The following is a description of a gene set: Human Gene Set: GOBP_PROTEIN_TRANSPORT studied in species Homo sapiens The directed movement of proteins into, out of or within a cell, or between cells, by means of some agent such as a transporter or pore., and this is the list of marker genes: YIF1A, SNX12, RGPD5, TCIRG1, AP3S2, ADIPOQ, HPSE, WASHC2C, ARF1, SRP54, AP5B1, VTI1A, RAB3A, ARFGEF2, COPZ1, TUNAR, SNAP91, PEX1, DENND1B, OAZ3, VPS37A, CDKN2A, OPRM1, CD200, TNPO1, TIMM10, TOM1L1, CDK5, APP, ARL8B, SNX8, VMP1, STX18, TANGO2 (transport and golgi organization 2 homolog), G6PC2, S100A13, SNX27, SFT2D3, CHMP4C, MYOM1, GPR68, ARRB1, TGFB1, SORT1, MYO5A, COPB1, NUP88, TVP23B, GFAP, EDEM2, PPIA, TVP23A, TRAM1, SNX9, F2, FAM3B, ZFAND1, SLC8B1, MLXIPL, NOTCH1, SOX4, GPLD1, ARFGAP2, UMOD, ACSL3, PORCN, EHBP1, PHPT1, USE1, PAFAH1B1 (NCBI Gene Id 5048), MIR130B, AP3M1, RSAD2, RHBDF1, TOM1, TNF, BET1L, CNIH4, TOMM6, RAB1C, RIMS2, ITPR1 (NCBI Gene Id 619543), IPO8, TAP1, PCSK5, STX8, ZW10, RIMS1, TRIP11, LIN7A, REST, TMED2, PKD1, TIMM23, TIMM17B, LRP1B, LRP1 (LDL receptor related protein 1), BRSK2, CDK1, PPP3CA, NPIPA1, KPNB1, LRRC8A, ZIC1, FOXA2, SAR1A, SURF4, TOMM20L, SEC61A1, NR0B2, PTPRN2, SNX31, PRF1, COG2, ASTN2, SLC9B2, GPER1, KIF20A, CANX, SCAMP5, TMED6, SPIRE2, F2RL2, CPT1A, EXOC6B, BLOC1S6, GOLPH3, MIR301B, ACTN4, TNPO3, FRAS1, FUT10, DNAJC13, NPFF, NR1D1, LONP2, RILP, PDIA4, SEC24C, ANGPT1, CETN3, FAF2, RAB1A, VPS45, EXOC6, JAKMIP1, CLU, FHIP1B, MAPK14, SNX20, UBR5 (ubiquitin protein ligase E3 component n-recognin 5), CEP41, P3H1, SEC24B, TFAP2B, TIMM9, VAMP4, ACD, XPO4, NUP58, NCOA4, EIPR1, SEH1L (SEH1 like nucleoporin), ABCG1, ATG10, RABL2A, RAC1, TOMM22, SPRN, RAB3IP (NCBI Gene Id 64325), PARK7, PTPRN, KCNN4, PPARG, ACAP1, KDELR3, KPNA2, CYB5R4, ARRDC4, LMAN2, UBE2J1, PICK1, VPS39, RAMP1, GIP, VAMP5, IL10RA, MYRIP, PCM1, HSPB1, WASHC1, RGPD4 (RANBP2 like and GRIP domain containing 4), NAPB, VPS54, FKRP, LARGE1, GPR89A, DMAP1, AFM, HDAC3, XPO7, PRKCB, AP4M1, NMD3, IST1, RAB11FIP1, SAMM50, NUP205, NDP, NUP54, VPS13C, IFT20, EXOC2, CD3G, APPL1, MON2, WLS, TGFB3, INSIG1 (insulin induced gene 1), LRP2, NAGPA, MYO1D, CBL (Cbl proto-oncogene), FAM3D, LCA5, SERGEF, EGR2, KPNA4, SNX33, B3GAT3, CARTPT, GRIP2, PRKAR1A, GRPEL2, SNX22, CLTRN, ISL1, SIX3, ADTRP, AP3D1, PRAF2, ACVR1C, CRYZL2P-SEC16B, NPLOC4, RAB17, CHMP3, KDELR1, PEX12, CTSA (cathepsin A), RAB3B, TSG101, PEX5L, AIFM1, SH3TC2, VPS36, VAMP7, RABEP1, TSNARE1, CPLANE2, GOLT1B, SCRIB, AHCTF1, EMD, AP3S1, IPO9, WASHC2A, DNLZ, AMN, PITPNM1, KIF5C, DENND10 (DENN domain containing 10), HEATR3, SUMO1, VPS35, ANG, ARF6, CHMP5, CHMP7, CHMP4A, ARFIP1, COPG2, MIR148A, IER3IP1, RAB9A, BLOC1S3, SEC61G, YWHAE, GOLT1A, ADAR, HLA-DRB1, HADH, TAP2, AKAP8, STXBP5L, ASPH, IFT56, APPL2, C1QTNF12, GRIP1, STX3, TERT, CETN2 (NCBI Gene Id 812), GNAZ, MIR29B1, TTC8, GNAO1, EPM2A, PRR5L, ARHGEF5, NEURL3, WDR11, FRMPD1, NETO1 (NCBI Gene Id 81832), GHSR, STK3, LRRC7, NUP153, ZG16, GPR119, SMURF1, PREPL, MMP12, ING1, CELA2A, HFE, SLC2A2, SYNDIG1, PLK3, ARFRP1, EFCAB7, ARF5, DENND1A, VIPAS39, KCNJ11, SFT2D1, RAB26, SNAPIN, FCHSD2, RABEP2, RAF1, CTNS, TTN, NR1H3, AP1S3, TSC2, SYTL4, SYTL2, BCR, PSEN1, COG6, PEX6, ELMOD3, TIMM10B, ARFGAP3, NUP43, SEC61B, HSPA8, RILPL1, SNX21, SNX6, PEX10, RUFY3, TFRC (NCBI Gene Id 7037), FKBP1B, TOMM70, RAB11FIP2, SPTBN1, SREBF1, YIPF5, ATP2C1, NR4A1, STEEP1, ANK2, EXPH5, TRIM23, RAB5B, NEUROD1, DNM1L, LEP, SNX19, RAB11FIP5 (NCBI Gene Id 26056), CAV1, MYH10, PIK3R4, CTAGE4, PFKL, HNF4A, JUP, PCK2, NKX6-1, ARCN1, AAGAB, GHRL, CRH, DRD4, NUP37, APBA2, NPM1, KIF5B, SYTL1, RBM22, ATF2, DTX3L (deltex E3 ubiquitin ligase 3L), RAB3C, RAB2A, CHP1, TESC, ATP13A2, PKDCC, DGKD, TMEM167A, ARL11, PTPN1, PSMD9, SIX2, PEX19, REEP2, KCNA5, TM7SF3, NF1, AP4E1, LYPLAL1 (lysophospholipase like 1), VPS11, LTBP2, UEVLD, VIP, VTA1, RAB24, TUBA1A, HM13, TIMM44, RAB27A, PPP3R1, TACR2, MTTP, PRKCD, IPO4, PCID2, SNX7, CLN3, MCFD2, STX7, TCF7L2, DOP1A, GSK3B, MON1A, ACSL4, RANBP3L, RABGAP1L, HNF1B, KRT18, TIMM17A, MACF1, KIF3B, IFNG, SEC22C, GOSR2, TOMM40L, NEO1, CD24, RAB19, F2RL1, GNAS, IRGM, BMP6, TMED5, GPIHBP1 (glycosylphosphatidylinositol anchored high density lipoprotein binding protein 1), PDCD6IP, CBLN1, SEC22A, MIA3, MIR19B1, CLOCK, NUP155, CASR, EDEM1, IRS2, IL12A, NAPA, ARF4, MIR146A, AP3M2, BAG3, WWP2 (NCBI Gene Id 116013), VPS26A, IDH2 (NCBI Gene Id 3418), SFT2D2, SLC15A3, AP1B1, CAPN10, RAB7A, VCP, RAB39B, NACAD (NAC alpha domain containing), RIC1, EFNA5, HYAL2, HOOK1, E2F3, AP1AR, YKT6, NECAB3, SPAG17, IPO11, VPS13D, CCL5, STX5, HSP90B1, NUP98, RAMP3, CHRM1, SNX13, KIF17, IFI27, ANKLE1, NUP93, RABGEF1, GGA1, GOLGA7, ILDR2, WASHC4, JAK2, ABCA12, RAB22A, SCG5 (NCBI Gene Id 6447), STRADA, GOLPH3L, BCAP31 (B cell receptor associated protein 31), NECAP2, PEX26, CTAGE15, TMED1, RAPGEF4, RHOB, UNC13B, PEX14, SNAP29, GCG, MED1, SLC7A11, SIRT4, SERP1, CLIP3, TIMM50, SNX15 (sorting nexin 15), STRADB, EDNRA (endothelin receptor type A), CD36, COG7, ADAMTS9, STX16, MLC1, IFIT1, ENSA, RAN, ARL4D, TRPA1, ADRA2C, VPS37B, ZFAND6, MIA2, RAB11B, RPAIN, COG1, MACIR, MTCH2, CLSTN1, AP1S2, PRKN, SNX32, ATG4C, BLZF1, GOLGA4, SNX1, BMAL1, NASP, RAB23, VPS37D, KCNB1, NLGN2, AP5M1, LYST, HSPD1, ERP29, KPNA3, MVB12A, EXOC7, AP5Z1, MX2, CLTA, COG3, ARL6IP5, PLEKHF2, RAB25, BECN1 (beclin 1), RAB41, TLK1, RAB10, SCFD1, VPS33A, TMED10, KIF5A, GDI2, CDKN1A, RAB1B, ARL6, AKTIP, PTPN14, NUP133, BBS5, VPS33B, AGAP1, CCDC22, HGS, SMAD3, TIMM13, TOMM20 (NCBI Gene Id 9804), FGG, DNAJC1, NDFIP2, SELENOS, TMEM115, OAZ2, VLDLR, CD38, VPS8, ATG4B, UHMK1, MTX2, CBLN4, STX1B, TMEM132A, APOE, SNX14, PML, MIDN, AP2B1, APPBP2, RD3, NUP214, FRAT1, B4GALNT2, PCLO, SFN, GPR27, CCHCR1, ABRA, DOC2B, SPIRE1, HEATR5B, CHMP2A, ARL5C, ATG7, RANGRF, MICALL1, UCN3, SNX17, GABARAP, CD81, CALR, TM9SF4, BBS2, UCP2 (NCBI Gene Id 7351), CFL1, GGA2, CADPS, NXF1, ZMAT3, RABL2B, PEX16, WASH3P, ARRDC2, NUP50, AP4B1, SELENBP1 (selenium binding protein 1), HERPUD1, EI24, TRARG1, CD63, DAB2, ABAT, ZBED6, PRKCA, SVBP, RACK1, RAB29, SCAMP2, SYS1, SENP2, SNX4, ORAI1 (ORAI calcium release-activated calcium modulator 1), SELENOT, SLC7A6OS, HOOK2, MC4R, PRKCE, TIMM8A, SNX11, RAB12, AP1G2, TFR2, BMP4, ENTR1, PPM1F, SLC51B, SHH (NCBI Gene Id 6469), AAAS, GDI1, MIR199B, FOXO1, P2RX7, GLUD1, LCP1, MIR30C1 (NCBI Gene Id 407031), TOMM7, RAB28, RFX6, TMEM97, PIK3R2, B2M, TMED9, RIPOR1, OAZ1, ADORA2A, AUP1, CHCHD4, SRPRA, ARL4C, STX19, IFT27, POM121, F2R, GRIPAP1, BCL3, RAB3IL1, RANGAP1, STX17, NADK, NUP188, UFD1, SDAD1, KPNA1, YOD1 (YOD1 deubiquitinase), AP2A1, PLA2G1B, APOD, GPR89B, KCNQ3, CPLX1, FAM53A, NUTF2, NXT2, FAM53C, CCDC93, STX12, SYT7, NFKBIA, TRMT10B, SEC24D, APBA1, NOS2, RGPD3, ARF3, SCG2, COG5, ARHGEF2, GOPC (NCBI Gene Id 57120), TMEM30A, CHMP2B, DUOXA2, ANP32B, IPO7, NUP160, ELMOD1, RRBP1, NMU, OPTN, ICE1, SLU7, CAMSAP3, RPH3AL, NECAP1, CCDC91, RAB32, BBS7, SACM1L, CHMP6, TANGO6, PLEKHA8, AGK, DERL1, CTAGE8, ARL17B, PAM16, IL1B, XPOT, COPZ2, STAM2, SMAD2, GLE1, STAM, CPLX3, RBM4, DNAJC14, VAMP8, C1QTNF5, STX11, UBAP1 (NCBI Gene Id 51271), REP15, BET1, BBS4, HIF1A, CHMP1A, ATP6AP1, IL13, RABL3 (NCBI Gene Id 285282), STXBP1, DAG1, ATG14, ADCY5, PARP11, AP3B1, SNUPN, NR1H2, NDEL1, AP1M1, PCNT, RINL, OR51E2, SEC23IP, PREB, MYO7A, PEX13, ARFIP2, C2CD2L, SEC16B, RAB6C (NCBI Gene Id 84084), C1QTNF3, ANK3, CDH1, IFT25, MLPH, FMN2, ARL14, VPS26B, SIRT6, PIK3R1, SLC35D3, PEX2 (NCBI Gene Id 5828), PDX1, IPO13, BAIAP3, MAMDC4, KPNA5, CHML, CUBN, ANXA13, LAPTM5, NUP62, RAB8B, GLP1R, UFM1, SLC4A8, NUP85, CLSTN3, AP1G1, NSG1, RAB6B, GAS6, HAP1, VPS50, COPA, TRAF3IP2, HPS6, ZDHHC17, NPAP1, ARRDC1, MAVS, SEC13, AP1S1, FUZ, FUT11, PDCD6, PPM1A, KIF13A, TIMM21, ARHGAP1, ANKRD1, CDK16, ZFYVE16, PRKACA, GCK, SYT4, HOOK3, NGFR, COL1A1, SNX16, SLC12A2, HCAR2, BBIP1, SIL1, SNX24, M6PR, TMEM30B, GNPTAB, TBC1D5, STX10, TIMM29, SEC62, RAB3D, CALCRL, CADPS2, INS, ABCA1, EXOC1, PFKFB2, BBS1 (Bardet-Biedl syndrome 1), LMAN2L, PGRMC1, TNKS, CAVIN1, MAP1LC3C, PTPN11, NR1H4, TBC1D13, ENY2, RILPL2, DMBT1, NUP35, RAB27B, EXOC4, VEGFC, OS9, VSNL1, ERLEC1 (endoplasmic reticulum lectin 1), SCARB2, AP1M2, SORCS2, STXBP4, DERL3, ASPSCR1, GUK1, SORL1, ANO1, RINT1, NDFIP1, SYVN1, CABP1, UNC119, DERL2, YIF1B, PTPN23, AP5S1, MTM1, POLA2, MDFIC (NCBI Gene Id 29969), MIR766 (microRNA 766), RAB5A, STX2, TBC1D17, RP2, TRPM4, DNAJC27, SNX25, XPO1, PEX7, AP2M1, NDUFAF2, FGB, WASHC3, SNAP25, SCAMP4, MIR199A1, AGAP2, RTN2, CHP2, CD74, PGAP1 (post-GPI attachment to proteins inositol deacylase 1), NXT1, MTNR1B, APOB, RAB4B (NCBI Gene Id 53916), ADRA2A, STXBP2, CYP51A1, SYK, BARD1, IL1RN, DNAJA1, SYTL5, LAMP2, SUCNR1, AKAP5, DENND4C, AP2A2, GORASP1, RAB11A, CHRM3, CHM, RAB4A, XPO5, PEX5, HSPA5, UNC119B (NCBI Gene Id 84747), SNX30 (NCBI Gene Id 401548), GRPEL1, GAL, SEC31B, IL1A, SLC16A1, RGPD2, ARRDC3, POM121C (NCBI Gene Id 442581), COPB2, RAB14, PHAF1, RANBP17, MYH9, NUP42, MTCH1, PTTG1IP, TNPO2, PLEKHM1, SLC25A22, MPC2, FAM76B, HSPA4, RAB3GAP2, RAB38, TRIM3, RGPD8, NNAT, TLR4, RAB6A, SLC15A4, SEC22B, ZFAND2B (NCBI Gene Id 130617), RAB5C, CBLB, CMTM6, DRD2, CSK, EDNRB, TMED4, CCDC186, AZGP1, VPS26C, PEX3, INHBB, ADCYAP1, TIMM22, FAM53B, DNM2, STX1A, CEP290, RAB7B, TMEM9, AFG2B, RGPD6, LYPLA1, SEC61A2, GCKR, DYNLT1, ACVR2B, C17orf75, RAB33B, C2CD5, RANBP6, CLTCL1, CORO7, RAB6D, STEAP3, GCC2, PIM3, ATG4A, TIMM23B, ARRDC5 (arrestin domain containing 5), SNX3, LRSAM1, MBTPS1, VPS18, RAMP2, DNAJC15, IRS1, ARFGEF1, ARL5A, IGF1, NDUFA13, NEURL1B, SYBU, BMP8A, LMNA, ZC3H12A, MIR19A, MIR93, DTNBP1, RAB37, SELENOK, CTDSPL2, SIRT7 (NCBI Gene Id 51547), SLC15A5 (solute carrier family 15 member 5), PLCB1, PARD6A, CAMK2G, IFT22, MAFA, CTAGE9, APBB3, SEPTIN8, SPG11, RAB21, FFAR1, JAGN1, SLC15A1, STAT3, RCN3, APBB1, RAB11FIP3, TIMM8B, SAA1, SEL1L, GABARAPL2, MCOLN1, ATG16L1, TMED3, RABIF, MYO6, SAR1B, LRRK2, YWHAH, COPG1, CD2AP (NCBI Gene Id 25916), PIK3C3, MCOLN2, CAMK1, TRAM1L1, ATG16L2, GPRC6A, LIN7C, MAP1A, CD33, DNAJC19, SLC1A1, CFTR, TVP23C, NUP107, GNPTG, PHB2, STXBP3, FRMD4A, GNAI1, CLTC, UBE2Q1, ADAM8, FFAR2, EXOC3, ATG4D, ERC1, MCU, RGPD1, HMGCR, EHD1, BICD2, FRAT2, PDE8B, FERMT1, WASHC5, SEC24A, RAB39A, HSPA9, FGA, EHD3, USP9X, MON1B, GNA11, ARL1, HNF1A, KCNK16, SNX2, KDELR2, CEP131, RUFY1, EIF4ENIF1, STK4, VPS41 (NCBI Gene Id 27072), VPS4A, USO1, NACA, GAPVD1, SYTL3, KRT20, SUFU, SEC23A, PPT1, BLK, UBAC2, PKIG, COMP, OSBP, DOP1B, PPID, COG4, CLTB, KPNA7, RSC1A1, TOM1L2, AP4S1, ALOX5, VPS13A, TREM2, VAMP2, HSP90AA1, MDM2, NUP62CL, TXNIP, ADCY8, TENM1, FGF9, CENPF, LMF1, MTX1, KIF18A, MCM3AP, RAB15, IPO5, PLA2G6, GPM6B, ARFGAP1, PFKM, TRIM37, RAB8A, DESI1, ARL4A, TOMM5, TMED7, TOMM40, MVP, COMMD1, RAB2B, LMAN1, KIF3A, SQSTM1, RAPGEF3, LIN7B, AKT1, YWHAB, VPS4B, MVB12B, ROMO1, RFFL, VPS35L, KTN1, FLNA, PHAX, SEC23B (SEC23 homolog B, COPII coat complex component), PER2, PDCD10, COMT, ITSN1, GSDMD, ADAM9, AHCYL1, VTI1B, EIF2D, CTAGE1, RAB36, SMO, ZPR1, SLC30A8, EPHA5, DRD1, NACA2, TLR2, SNX5, BCAP29, HERC2, RHBDF2, TARDBP, TGFBRAP1, DLG2, TGFB2, COPE, EPS15, PPP3CB, KPNA6, CCN3, PRKD1, SCAMP3, CNST, RPGR, SEC16A, MIR128-1 (NCBI Gene Id 406915), AFTPH, ANKRD27, ARHGAP33, ARL3 (ADP ribosylation factor like GTPase 3), SYNRG, STX4, POM121B, STX6, RHBDD1, CTAGE6, GLI3, TRIM28, GIPR, CHMP4B, NUP210, B3GLCT, ELAVL1 (ELAV like RNA binding protein 1), GOLGA2, GBF1, ERGIC3, OLFM2, FAM91A1, TP53, VPS16, VPS52, POM121L2, SEC31A, AKIRIN2, UBE2G2, DPH3, NEDD4, TRAM2, TMEM129 (transmembrane protein 129, E3 ubiquitin ligase), OXCT1, LSG1, ATG3, SCFD2, ANKRD50, TRH, IL33, RAB20, NDC1, TXN, KLF7, VPS29, UNC93B1, PPP1R10, AP2S1, PPY, BBS9, RHBDD3, RANBP3, CHGA, CWH43, RAB31, GJA5, EP300, SCAMP1, ACHE, MSR1, KIF20B, STXBP5, VGF, SNCG, SRI, LMTK2, TPR (translocated promoter region, nuclear basket protein), HCLS1 (hematopoietic cell-specific Lyn substrate 1), TRPM5, DUOXA1 (NCBI Gene Id 90527), VPS51, RAB18, ABCC8, SNAP23, MCL1, VPS53, KCNJ8, RAP1GDS1, XBP1, ABCB9, SLC15A2, ARRB2, SIDT2, RAB34, PKIA (NCBI Gene Id 5569), FAM3A, BTF3, PRP4K, IL12B, EXOC5, AP3B2, ATP1B1, ATP13A1, NBAS, ARL5B, PRICKLE1, RAB13, ARHGAP44, RANBP2, APBA3, GOSR1, ECT2, RFTN1, CHMP1B, RAB43, MYO18A, GFER, DENND2A, HDAC6, LRP5, VPS25 (vacuolar protein sorting 25 homolog), CRY2, SSTR5, SVIP, MTX3, DRD3, MYO5B (NCBI Gene Id 4645), PLEK, MAPK8IP3 (NCBI Gene Id 89855), PPARD (NCBI Gene Id 5467), AACS, RPL23, NAPG, RAB9B, RAB35, EXOC8, COG8, SNX18, RBSN, CSE1L, RPH3A, UQCC2, APOBEC1, BAD, VAMP3, VPS37C, GGA3 (NCBI Gene Id 23163), IL6, RBP4, NSF, HIKESHI, DYNLL1, TMCO6, RFX3, TECPR2, XPO6, ARL8A, BSG, ZDHHC2, SEC63, KLHL20, HIP1, SNF8, CTTN, SNX10, SP100, SIRT3, VPS28